Given this list of marker genes KLHL25, IFNG, PLA2G2D, IL2RG, FOXP3, KCNK18, HLA-DRB1, TOX, HLA-DRA, LGALS9, FUT7, here is a description of the gene set: Human Gene Set: GOBP_CD4_POSITIVE_CD25_POSITIVE_ALPHA_BETA_REGULATORY_T_CELL_DIFFERENTIATION studied in species Homo sapiens The process in which a precursor cell type acquires the specialized features of a CD4-positive, CD25-positive, alpha-beta regulatory T cell.